Given this list of marker genes Runx1, Map2k7, Madcam1, Ninj1, Cebpa, Ccne1, Itgal, Srpk1, Tfrc, Htr3a, Blnk, Hbb-y, Mst1r, Mecom, Map6, Rora, Il17ra, Fli1, Mknk1, Ptpn13, Kif3b, here is a description of the gene set: from publication Numata A, Shimoda K, Kamezaki K, Haro T, Kakumitsu H, Shide K, Kato K, Miyamoto T, Yamashita Y, Oshima Y, Nakajima H, Iwama A, Aoki K, Takase K, Gondo H, Mano H, Harada M (PMID 15664994) Mouse Gene Set: NUMATA_CSF3_SIGNALING_VIA_STAT3 The Janus kinase (Jak)-Stat pathway plays an essential role in cytokine signaling. Granulocyte colony-stimulating factor (G-CSF) promotes granulopoiesis and granulocytic differentiation, and Stat3 is the principle Stat protein activated by G-CSF. Upon treatment with G-CSF, the interleukin-3-dependent cell line 32D clone 3(32Dcl3) differentiates into neutrophils, and 32Dcl3 cells expressing dominant-negative Stat3 (32Dcl3/DNStat3) proliferate in G-CSF without differentiation. Gene expression profile and quantitative PCR analysis of G-CSF-stimulated cell lines revealed that the expression of C/EBPalpha was up-regulated by the activation of Stat3. In addition, activated Stat3 bound to CCAAT/enhancer-binding protein (C/EBP)alpha, leading to the enhancement of the transcription activity of C/EBPalpha. Conditional expression of C/EBPalpha in 32Dcl3/DNStat3 cells after G-CSF stimulation abolishes the G-CSF-dependent cell proliferation and induces granulocytic differentiation. Although granulocyte-specific genes, such as the G-CSF receptor, lysozyme M, and neutrophil gelatinase-associated lipocalin precursor (NGAL) are regulated by Stat3, only NGAL was induced by the restoration of C/EBPalpha after stimulation with G-CSF in 32Dcl3/DNStat3 cells. These results show that one of the major roles of Stat3 in the G-CSF signaling pathway is to augment the function of C/EBPalpha, which is essential for myeloid differentiation. Additionally, cooperation of C/EBPalpha with other Stat3-activated proteins are required for the induction of some G-CSF responsive genes including lysozyme M and the G-CSF receptor. Target genes for STAT3 in CSF3 signaling during myeloblast differentiation to neutrophils. studied in species Mus musculus